The following is a description of a gene set: Human Gene Set: MIR4801 species: Homo sapiens Genes predicted to be targets of miRBase v22 microRNA hsa-miR-4801 in miRDB v6.0 with MirTarget v4 prediction scores > 80 (high confidence targets). from publication Chen Y, Wang X (PMID 31504780), and this is the list of marker genes: SFMBT2, WEE1, OTUD1, SPAG16, CCDC85A, MACO1, SORL1, CHRDL1, ADRB1, ZFHX3, ZNF804A, TMA16, USP1, VSNL1, TMX4, UBE2H, TP53TG3B, IYD, ZNF605, HOXA5, RB1, SF3B1, GLRA2, DDX3X, EPHA5, LSM4, HSPD1, NOVA1, GAD2, GABRA6, MOSPD1, SPHKAP, SPOCK3, PABIR3, NUP54, HIVEP1, NF1 (neurofibromin 1), PCDHA13 (NCBI Gene Id 56136), SPRY4, ARHGAP32, NDUFAF6 (NADH:ubiquinone oxidoreductase complex assembly factor 6), PCDHA11, PHLDA1, UCK2, PAPOLG, UBE2B, SCGB2A1, SMG7, DIPK2A, ZNF652, HACD3 (NCBI Gene Id 95112), USP24, PARPBP, HSPH1, UBE3A, FAM193A, PTPRK, PCDHA8, GORASP2, PPP1R15B, PI4K2B, BMPR1A, ZNF382, CCDC184, PCDHA3, SEC23IP, PUM2, JAG2 (jagged canonical Notch ligand 2), ALG10B (NCBI Gene Id 493903), UGT2A3, RIMKLB, SGTB, ELL2, BRWD3, SNRPB2, CTDSPL2 (CTD small phosphatase like 2), ANKRD27, CXCR4, ADAMTS10, ERC2 (NCBI Gene Id 26059), PCDHAC1, KBTBD8, PCDH9, CLEC14A, SRP68, PPP4R2, NETO1, PHC3, TNFRSF19, TEAD3, ARNT, QRICH1, RAB9B, SLC26A5, PSD3, BAZ1B, DIP2B, MAP7D3, ZC3H6, RNF11, NUFIP2, RTN4R, SIN3A, CYRIA, RBX1, MEX3D, PTGFRN (NCBI Gene Id 5738), TRIO, HIPK1, MECP2 (NCBI Gene Id 8274), ASAH2B, BAZ2B, DNAJC27, IMMT, PCDHAC2, KSR2, ARL5A, PCDHA12, AGFG1, SYT1, TMEM106B, NWD2, CCNL1, KIF26B, MEST, RANBP3L, SLC16A1 (solute carrier family 16 member 1), PLIN1, SAMSN1, IRF5, FBXL5, PUM1, ZNF706, UBE2D2, FAM199X, USPL1, FAM117A, DACT1, TULP4, PRTG, PTPN9, HECTD2, NRP1, ZC3H12C, CNOT1, HMGB2, NUDT16, CLDN8, NFAT5, PCDHA10, MPDZ, SPTLC1, TMEM35A, MCHR2, TENT4B, SGIP1, INO80D, CCDC71L, PCDHA4, LRRTM3, NUTF2, DACH1, CNOT7, NOTCH2 (notch receptor 2), DHX38, NDRG4, BMPR2, NAP1L3, NRIP3, C15orf62, CNTRL, TP53TG3D, CCL23 (C-C motif chemokine ligand 23), PCDHA1, SRGAP2, ASIC2, LRP12, ERLIN1, ST8SIA4, AUTS2, DOCK10, PCDHA2 (protocadherin alpha 2), ZFR, CCDC136 (coiled-coil domain containing 136), GPM6B, GTPBP3, RBM27, ABLIM3, SPCS2, UBR3, SPC24, RC3H1, RNF220, ANK3, HECTD1, DGKE, DNAI4, FAT3, NIPSNAP2, ABHD13, TSC22D2, WDR47, NRN1, TBC1D8B, TOB1, TP53INP1, YWHAH, CSNK1D, RORA (RAR related orphan receptor A), UBA2, PCDHA7, RNPS1, GOLGA7, RNF2, PNN, ATP2B4, PTPN4, RAP1A, ACTR10, CACNA1C, AKAP9, USP38, GPM6A, MBNL3, PMCH, PHF3, TATDN2, DUSP4, CNNM4, POLR1B, TLX1, ZMYND8, FGF13, PRKAG2, MFSD6, CRKL, TP53TG3 (NCBI Gene Id 92873), ZNF143, TOP1, ABI1, LUC7L3, LDHA, ZIC4, FAM91A1, RIMS3, PCDHA5, RRAS2, FOXO3, MSR1, RNF139, ZFPM2, NR4A1, RYBP, LRRTM4, ITGB5, NAT1, SCG2, SEH1L, RFX3, PCDHA6, CFAP61, DOCK3, DCAF5, NUAK2, PITPNB, BIRC6, ROBO2, TXLNG, ZFP14, ZCCHC17, NDFIP1, NECTIN1, CERT1